Given this list of marker genes MYH7, MNAT1, ADRA1A (adrenoceptor alpha 1A), MYH10 (NCBI Gene Id 4628), HAND2, BMP10, NKX2-5, TCAP, APELA, MYH6, APLNR, CHD7 (chromodomain helicase DNA binding protein 7), MEF2D, SCUBE1, here is a description of the gene set: studied in species Homo sapiens The process whose specific outcome is the progression of the adult heart over time, from its formation to the mature structure. Human Gene Set: GOBP_ADULT_HEART_DEVELOPMENT